The following is a description of a gene set: species: Homo sapiens Human Gene Set: HP_PALPEBRAL_THICKENING An increased thickness of the eyelid not related to acute inflammation. Palpebral thickening, and this is the list of marker genes: DPYD, BRAF, ANTXR1, TASP1, NAA10